Given this list of marker genes Sntb2, Irf9, Cx3cl1, Mpg, Mast4, Sertad2, Carf, Xirp1, Cyth1, Nfatc2ip, Pdzd8, Sybu, Borcs7 (NCBI Gene Id 75899), Zfp503, Galnt7, Tef, Rnft1, Cyp4a31, Fcrl2, Lrrc47, Akt3, Hoxa5, Zfp831, Rnf44, Med29, Trim9 (tripartite motif-containing 9), Kmt2a (NCBI Gene Id 214162), Slc25a37 (NCBI Gene Id 78702), Ldb1, Vmn1r58, Akirin1, Epn2 (epsin 2), Col5a1, Ttc12, Nr5a2, Rab3c, Iffo2, Pramex1, Fanci, Clec3a, Trim35, Cyp4a10 (cytochrome P450, family 4, subfamily a, polypeptide 10), Dab2, Osbpl7, Mtpap, Slc1a4, Nfat5, here is a description of the gene set: Mouse Gene Set: MIR_6938_5P from publication Chen Y, Wang X (PMID 31504780) Genes predicted to be targets of miRBase v22 microRNA mmu_miR_6938_5p in miRDB v6.0 with MirTarget v4 prediction scores > 80 (high confidence targets). studied in species Mus musculus